Given this list of marker genes Grb14, Tmprss12, Ednrb, Lrrk2, Ret, Mir132, Nppc, Trim58, Gsk3b, Mtor, Tbx6, Bcl2, Wee2, Map3k13, Sirt2, Opa1, Shb, Tcp11, Kif14, Grip2 (glutamate receptor interacting protein 2), Ngf, Mir212, Aurka, Nox1, Clec7a, Bnc1, Bcl11a, Rac3, Adam7, Rac1, Npr2, Mir133b, Spinkl, Dleu2, Runx1, Tcp11x2, here is a description of the gene set: Any process that modulates the frequency, rate or extent of cell maturation. Mouse Gene Set: GOBP_REGULATION_OF_CELL_MATURATION species: Mus musculus